The following is a description of a gene set: species: Homo sapiens Abnormal hair pattern An abnormality of the distribution of hair growth. Human Gene Set: HP_ABNORMAL_HAIR_PATTERN, and this is the list of marker genes: RPL5, DOCK6, MEOX1, KMT2A, COG5, CDC42BPB, SLC12A6, NSUN2, RPL18, STT3A, VPS13B, GATA1, LMX1B, APC, PEPD, SMPD4, RIT1, SH2B1, HPGD (NCBI Gene Id 3248), JARID2, MADD (NCBI Gene Id 8567), NSD2, SMARCB1, RBM10, SNORD116-1, MAPK1, TGM3, PGAP1, EBF3, PHF8, KCNN3, PORCN, PIGA, USB1, MAPRE2, ERI1, WASHC5, PEX19, PPP1R15B (protein phosphatase 1 regulatory subunit 15B), SALL4, LMNA, ZFX (zinc finger protein X-linked), SRCAP, KCNJ8, KCNH1, MEIS2, RAD21, HDAC8, SPEN, HRAS, RPL31, CCDC22, SMO, FOXP1, FOS, MAFB, LETM1, ASH1L, NOTCH2, TCF12, SYT1, PTPN11 (protein tyrosine phosphatase non-receptor type 11), PEX6, RPL11, CAV1, SOX11, RPL9, ALX1, TBX15, BICRA, CREBBP, UBE2A, FRAS1, SF3B4, COL17A1, SLCO2A1, ACTB, TECPR2, GMPPA, HS2ST1, H3-3A, SLC32A1, FGFR2, SPRED1, ARHGEF2, SNORD115-1, KRT83, PIK3C2A, WNT4 (Wnt family member 4), FRMD4A, SMARCA2 (NCBI Gene Id 95083), NPAP1, APC2, MED27, GDF3, MAP2K1, RAB18, SLC6A1, IFT140, OGT, CBL, MRAS, FREM1, NUDT2, DPH2 (diphthamide biosynthesis 2), NEXMIF (NCBI Gene Id 340533), EFEMP1, GDF11, CAMTA1, EFNB1, NR3C1, CDH2, PWRN1, NECTIN4, ECM1, KDM1A, CNBP, PPP1R13L, INTU, PRKD1, LZTR1, RPS7, SOS1, LIG4, CUL4B, PIK3CD, AP2M1, TSC1, MAN1B1, MYO18B, NBN, SIN3A (SIN3 transcription regulator family member A), SETD2, UBR1, HUWE1, ALG11, RERE, NRAS, CHRNG, MID1, RPS29, AFG2B, WBP11, IFIH1, RBL2, INSR, SHOC2, MAP2K2, CHN1, FBXO11, LRP2, CPLX1, ADNP, ARID1B, NELFA, TBC1D24, RPS28, KRT81 (NCBI Gene Id 3887), CD96, KRT86, NIPBL, KCTD1, HYOU1, RALGAPA1, SPOP, NOVA2, PPP1CB, RNU4-2, KDM4B, RRAS, H4C5 (H4 clustered histone 5), DHX30, RAF1, ARID2, NF1, PPP2R3C, TAF6, RHOBTB2, SPRED2, RPS19, EMC1, HSPG2 (heparan sulfate proteoglycan 2), HDAC4, TTC5, CHD2, H1-4, DLX4, FGFR3, TMCO1, KMT2D, STAMBP, SETD5, XYLT2, TSR2, FLNA, NFIX, POLA1, SLC9A7, PPARG, TBL1XR1, ALG12 (NCBI Gene Id 79087), SATB1, ANTXR1, NANS, MBD5, BLM, PPP2R1A, SLC2A1, ARID1A, CAVIN1, FAT4, GNE, FGFRL1, ATP6V1B2, ADA2, ZIC1, ANKRD11, KDM6A, PADI3, ALX3, AIFM1, RRAS2, ADARB1, NAA80, IGF1, KDM5C, FKRP, DEAF1, TBX2, ALG9, DOCK7, AEBP1, RPS27, PACS1, TRAF7, AGPAT2, GJA8, ALMS1, ACTG1, TRIO, TBC1D20, SMARCA4, TP63, RPL15, RPL26, TCF4, RPL27, ASXL1, SLC35C1, CAMK2A, KRAS, CNOT3, BRCA1, TFAP2A, UBAP2L, GRIP1, CDH3 (cadherin 3), PQBP1, IL2RA, ARX, IRX5, RPS10, SCNM1, CDK5, DSG4, ALDOA, KNSTRN, SOX4, TWIST1, CIT, BSCL2, RPS15A, CAPRIN1, EDEM3, B3GAT3, RPS24, TCOF1, IKBKG, DPM2, SMARCD1, MAP3K7, ANKRD17, DMPK, ZMPSTE24, MED12, EXOSC2, PEX1 (peroxisomal biogenesis factor 1), LAMB3, HR, CWC27, STAG2, KREMEN1, PWAR1, EP300, UGP2, SMC1A, PIGK, BRAF, SPECC1L (sperm antigen with calponin homology and coiled-coil domains 1 like), SMC3, RAB3GAP2, WRN, ASCC3, SYNGAP1, SLC25A24, NOTCH3, BRD4 (bromodomain containing 4), ERMARD, ABCD1, NSD1 (NCBI Gene Id 6797), FILIP1, MYH3, AIRE, THOC6, RPL8 (NCBI Gene Id 6132), GDF6, CPOX, NEPRO (NCBI Gene Id 285338), KRT85, SMARCE1, TWIST2, FRMPD4, RAB3GAP1, FREM2, HERC2, PIGG, CLCN3, POLR1B, CDH1, MKRN3, MAB21L1, RPS17, MEGF8, SVBP, SLC26A2, TRAC, VPS33A, HEATR3, TRMT10A, GJA5, ZNF699, YY1, RASA2, GNB2, LRPPRC, FGD1, PRDM13, ABCC9, CTBP1, STXBP1, CTCF, SRY, RPL35, MAN2B1, TRPM3, SCN1A, MED13L, CHST3, RPS20, SOS2, DPF2, RPL35A, SMARCC2, POLR1D, EBP, VPS51, CDK13, MAGEL2, RPS26, CNTNAP2, ITGB4, HNF1B, XRCC4, POLR1C, CCNK, COG7, ASL, ZC4H2